Given this list of marker genes EXTL3, PDPN, HUWE1 (NCBI Gene Id 54789), UFC1, FBN1, AMMECR1, LMX1B, LTBP3, SETBP1, CDC45, GBA1, BCR, HEATR3, ZMIZ1, TPM2, POLR3A, GNAI3, DLK1, RERE, PPP1R15B, SLC26A2, MCM5, ORC4, NFIX, DONSON, CRKL, CHSY1, SPEN, MYBPC1 (myosin binding protein C1), ATP6V0A2, TRMT5, NALCN, APC, CDC6, WNT3, MEG3, GRB10, TP63, H3-3A, OTX2, PRKCZ, SCYL2, PQBP1, SKI, STXBP1 (NCBI Gene Id 6812), TBX1, HSPG2, LMNA, MED12L, MDM2, FBXO11, GABRA3, CENPT, CEP57, MMP1, POLD1, MTX2, COG7, NOTCH2, RIPK4, POLR1C, GP1BB, IGF1R, SCN1A, LGI3, CCND2, TBX4, CCBE1, CASZ1, SLC25A24, DHCR24 (NCBI Gene Id 9800), NONO, GJA1, SOX6, RTL1, PIK3R2, RNH1, LEMD2, UBE3B, TCOF1, NEDD4L, MAPRE2, FAM20C, MAPK1, PTEN, CAV1, NFIA, CDT1, CANT1, ORC1, SCARF2 (NCBI Gene Id 91179), POGZ, CHD6, TRIP4, BRPF1, PLCB4, TWIST1, EP300, EIF4A3, MUSK, B4GALT7, SON, GSC, UFD1, TTN, CAMTA1, PHACTR1, TLK2, ECEL1 (NCBI Gene Id 94923), PRDM16, CDK13, B3GAT3, RAB3GAP1, OSGEP, PCGF2, COL2A1, COMT, ARVCF, HIVEP2, DCPS, POLR1B, GLB1, MMP23B, GABRD, COL11A2, PIGN, SP7, SKIC3, ATP6V1E1, DCHS1, GNB2, AUTS2, TRMT10A, CHST3, CRELD1, FILIP1, TNNI2, HDAC9, TAF6, NEB, EDN1, KIF7, DSE, MED12, HIRA, COL7A1, ORC6, AKT1, GMNN, SEC24C, SOX9, BBS7, SUPT16H, CREBBP, FREM2, KARS1, PRRX1, ZMPSTE24, SEPTIN9, CA2, MAPK8IP3, BMPR1A, SATB2, BCL11B, MADD, ASXL1, CTCF, RSPO2, SYNGAP1, PAX3, TMLHE, ZBTB20 (zinc finger and BTB domain containing 20), RREB1, PIEZO2, CACNA1C, BPNT2, MYL11, SEMA3E, UBE4B, FGFR2, PAFAH1B1, YWHAE, LUZP1, IARS2, POLR1D, MAF, TNNT3, TXNL4A, KCNAB2, COL3A1, RNF2, RTTN, KAT6A, AKT3, POU4F1, ALDH18A1, POR, COG1, PIGA (phosphatidylinositol glycan anchor biosynthesis class A), NAA80, CRLF1, CHD7 (chromodomain helicase DNA binding protein 7), RNU4-2, BMP2, RLIM, MYH3, FAT4, HECTD4, TBC1D20, AHDC1, RPL10, BIN1, RYR1, PTCH1, TGDS, SMAD4, CLCF1, CLCN3, ITGA3, MECP2, BPTF, SIN3A, JMJD1C, PIK3CA, ADAMTS3, ATAD3A, CHST14, PIGF, SH2B1, TUBB (tubulin beta class I), EIF4A2, RECQL4 (RecQ like helicase 4), SMS, CHRNG, SPEG, FLNA, SCNM1, COL11A1, here is a description of the gene set: studied in species Homo sapiens Human Gene Set: HP_NARROW_MOUTH Narrow mouth Distance between the commissures of the mouth more than 2 SD below the mean. Alternatively, an apparently decreased width of the oral aperture (subjective).